Given this list of marker genes ATP1A3, TBC1D2B, SREBF1, UFSP2, SEC23A (NCBI Gene Id 353367), ITPR1, NCDN, ZEB2, NR2F1 (NCBI Gene Id 7025), LRMDA, PPP2R5D, SCN4A, KIDINS220, HPDL, IRF2BPL, EMC1, B9D1, HOXB1, SLC25A1, CRB1, PIGV, LMNB1, SCN8A, PEX5, ATOH7, PHOX2A, ZEB1, TARS1, SCAF4, COL8A2, PUF60, PGAP2, SATB2, ABCC9, COL4A2, CLP1, COL25A1, POLG, FBXO28, LRPPRC, SOST, RRAS2, PWRN1, MYO9A, TMEM231, MPLKIP, TRIT1, SLC38A8, TELO2, CLCN3, MKRN3, HERC2, PIGY, SLC5A7, TUBB2B, MBD5, KDM6B, CARS1, BPTF, PRKAR1B, HMGB3, AHDC1, PIGN, RNASEH1, DPM1, SLC25A46, CLCN6, PWAR1, COL6A2 (NCBI Gene Id 1292), MPDZ, DDOST, KAT8, PIGW, DPP6, CDC42BPB, PIGT, PIK3R1, WDR45, PGAP3, GJA5, MED12, HPS3, TMEM222, TBX1, GTF2H5, CAMK2B, CHD8, LAGE3 (L antigen family member 3), CACNA1A, KAT6A, VSX1, EXOSC9, GLRB, ERCC2, B3GAT3, MADD, AGTPBP1, PI4KA, SNORD115-1, FAM149B1 (family with sequence similarity 149 member B1), KCNMA1, MYOD1, OFD1, PEX12, SNORD116-1, H4C3, ATAD3A, TTI1, PMM2, DLAT, H4C11, POLA1, CHMP1A, GJA8, AP1G1, SALL2, CYB5R3, ALG9, AMMECR1, RRM2B, ALG2, KIF7, VAMP1, GRID2, GBA1, ZSWIM6, RTL1, NPAP1, GTF2E2, ERCC3, ADAT3, SLC12A6, DDX59, AHCY, PIGL, COG1, LRP5, SLC1A3, VRK1, NTNG2, POU4F1, MAGEL2, GRM1, KIAA0753, PIGO, LMBRD2, GALC, CYB5A, PDE4D, GNB1, ZNF408, DDB1, ARPC4, SYT1, RORA, ANTXR1, COL6A3, PHGDH, AGRN, DLK1, PTEN, NEUROD2, SON, SNAP25, CHST3, EBP, APC, PLPBP, COL6A1 (NCBI Gene Id 1291), SLC35C1, SIAH1, COL13A1 (NCBI Gene Id 96775), EXOSC8, OVOL2, ROBO3, CDKL5, PPP1R21, ATIC, FBN1, KIF21A, MEG3, AARS1, CRELD1, SYT2, ATP1A2, NALCN, SOBP, GRHL2, ARHGAP31, TOPORS, COL11A1, NEXMIF, PYCR2, ADGRG1, ALG12, FBXO11, TUBA1A, PUS7, TMEM216, FZD4, CPLANE1, EXOSC3, PIDD1, HUWE1, SLC18A3, FOXP2, TUBB3, LGI4, EXOSC5, CHAT, COL12A1, IARS2 (NCBI Gene Id 55699), RNF113A, ASNS, PAK1, USP7, MECR, DYRK1A, TENM3, FRMD5, UBAP2L, TBC1D23, VPS50, COG8, NSD1, TCTN3, UNC80, RERE, GNA14, PCDHGC4, UFC1, PDE6D, FGF10, TBCK, PURA, BLOC1S3, here is a description of the gene set: studied in species Homo sapiens A manifest or latent ocular deviation in which one or both eyes tends to deviate nasally. Esodeviation Human Gene Set: HP_ESODEVIATION